Given this list of marker genes CASP9, CASP7, APAF1, XIAP, CASP3, CYCS, DIABLO, here is a description of the gene set: part of: SMAC, XIAP-regulated apoptotic response Second mitochondria derived activator of caspase/direct inhibitor of apoptosis binding protein with low pI (SMAC, also known as DIABLO) regulates XIAP function and potentiates caspase-3, -7 and -9 activity by disrupting the interaction of caspases with XIAP. Residues 56-59 of SMAC (DIABLO) are homologous to the amino-terminal motif that is used by caspase-9 (CASP9) to bind to the BIR3 domain of XIAP. SMAC (DIABLO) competes with CASP9 for binding to BIR3 domain of XIAP promoting the release of XIAP from the CASP9:apoptosome complex (Srinivasula SM et al. 2001; Salvesen et al. 2002). The binding of SMAC to the BIR2 and BIR3 regions of XIAP creates a steric hindrance that is essential for preventing binding of XIAP linker region with effector caspases CASP3 and CASP7 thus achieving neutralization of XIAP inhibition. The strong affinity for XIAP allows SMAC (DIABLO) to displace caspase-3, -7 from the XIAP:caspase complexes (Wu G et al. 2000; Chai J et al. 2001; Huang Y et al. 2003; Abhari BA & Davoodi J 2008). species: Homo sapiens Reactome Pathway: SMAC(DIABLO)-mediated dissociation of IAP:caspase complexes